The following is a description of a gene set: Binding to cholesterol (cholest-5-en-3-beta-ol); the principal sterol of vertebrates and the precursor of many steroids, including bile acids and steroid hormones. Human Gene Set: GOMF_CHOLESTEROL_BINDING studied in species Homo sapiens, and this is the list of marker genes: TSPO, STARD4, SLC38A9, CETP, APOD (apolipoprotein D), SOAT1, SYP, STARD3NL, NPC1L1, SOAT2, PMP2, NFE2L1, OSBPL2, OSBP2, SCP2, TSPO2, NINJ2, CD81, SIDT1, NPC2, OSBPL3, OSBPL6, ANXA6, MINAR2, GRAMD1C, PROM1, GPR155, TMEM97, VDAC2, SULT2B1, OSBPL8, GRAMD1A, STAR, APOC3, APOA2, ABCA1, STARD3, SCARB2, ERLIN2, PTCH1, PROM2, VDAC1, OSBPL1A, GRAMD1B, APOF, ERLIN1, NR1H3, STARD5, ABCG1, APOA1, NPC1, OSBPL10, CAV1, OSBPL5, OSBPL7